Given this list of marker genes IGKC, IGKV2-29, IGHV3-11, IGLV10-54, IGKV2D-30, IGLC1, IGHV1-46, IGHV3-53, IGLV6-57, IGLV2-8, IGKV2-28, IGLC3, IGKV3-20, IGHV4-39, IGLV1-40, IGHV3-7, IGHV2-70, IGLV3-27, IGLV4-3, IGHV7-81, IGHV1-69, IGHV3-33, IGHV4-34, IGLV1-47, IGKV2D-40, IGHV2-5, IGHV3-23, IGLV3-19, IGLV2-33, IGKV1-33, IGHV3-13 (NCBI Gene Id 28449), IGKV3D-20, C1QC, IGLV4-69, IGKV2D-28, IGLC6 (NCBI Gene Id 3542), IGLV2-23, IGLV1-44, IGLV1-36, IGLV8-61, IGHV3-48, IGHV3-9, IGKV1-12, IGKV1D-12, IGLV3-12, IGLV2-11, IGLV3-1, IGKV4-1, IGKV5-2, C1R, IGLV3-22, IGHV1-2, IGKV1-39, C1QA, IGLV11-55, IGLV2-14, IGKV3-11, IGHG1, IGKV1-17, IGHV, IGLV3-25, IGLV7-46, CRP, IGHV3-30, IGLV3-21, IGKV1D-33, IGLV4-60, IGLV1-51, IGKV1D-39, IGLV7-43, IGLV2-18 (immunoglobulin lambda variable 2-18), IGHV4-59, IGLV5-37, IGLV5-45, C1S, IGKV2-30, IGKV3-15, IGLC7, IGLV, IGHG4 (NCBI Gene Id 3503), IGKV1-16, IGKV1-5, C1QB, IGLC2, IGLV3-16, IGHG3, IGKV1D-16, IGHG2, here is a description of the gene set: C1, the first component of complement is a complex containing three protein species, C1q, C1r, and C1s. C1q is assembled from six identical subunits each of which consists of three homologous chains (A, B, and C). These chains form a globular domain at the C-terminus, followed by the "neck" and a coil in the "stalk." The six subunits are held together by the collagenous stalk parts (giving rise to the comparison of C1q with a "bunch of six tulips"). The stalks also interact with the tetramer assembled in a linear chain. Binding of an antigen to an antibody of the IgM or IgG class induces a conformational change in the Fc domain of the antibody that allows it to bind to the C1q component of C1. C1 activation requires interaction with two separate Fc domains, so pentavalent IgM antibody is far more efficient at complement activation than IgG antibody. Antibody binding results in a conformational change in the C1r component of the C1 complex and a proteolytic cleavage of C1r, activating it. Active C1r then cleaves and activates the C1s component of the C1 complex. studied in species Homo sapiens part of: Creation of C4 and C2 activators Reactome Pathway: Classical antibody-mediated complement activation